The following is a description of a gene set: Mouse Gene Set: GOBP_ISG15_PROTEIN_CONJUGATION The covalent addition to a protein of ISG15, a ubiquitin-like protein. studied in species Mus musculus, and this is the list of marker genes: Ube2e2, Ube2e1, Isg15, Ube2l6, Uba7